The following is a description of a gene set: Human Gene Set: HP_CYSTIC_HYGROMA studied in species Homo sapiens A cystic lymphatic lesion of the neck. Cystic hygroma, and this is the list of marker genes: TRAF7, NRAS, CHRNA1, PLXND1, RRAS2, MAGEL2, ESAM, RRAS (NCBI Gene Id 6237), RAPSN, TRIP11, LBR, LAMA5, HNRNPK, MRAS (muscle RAS oncogene homolog), RAF1, TGDS, BLTP1, TMEM216, SOS1, COL2A1, RIT1, CDC42BPB, WDR35, BRAF, FLVCR2, CEP55, DONSON, SPRED2, PTPN11, MCTP2, PIGS, FOXC2, MYOD1, FOXF1, ESCO2, LZTR1, SOS2, SLC18A3, CBL, SLC26A2, DLL3, MUSK, CHRNG, NUP88, IFT43, RASA2, KRAS, MAP2K1, KIF21A, MESP2, CHRND (cholinergic receptor nicotinic delta subunit), TUBA1A, DOK7